Given this list of marker genes NUP98, NLRP6, TP53, NUP153, WNK1, FMR1, SQSTM1, NLRP3, CAPRIN1 (NCBI Gene Id 4076), NEAT1, FUS, LIAT1, FAM81A, DAXX, NCK1, AR, ALKBH5, LGALS3, BRD3, PRNP, NFE2L2, WNK3, HNRNPA2B1, G3BP1, MKI67, SYT1, BLNK, NLRP1, DDX4, MYOZ1, MAVS, UBQLN2, G3BP2, FXR1, SOS1, CGAS, ADGRL3, TARDBP, ZAR1, CARD8, EZH1, CCNT1, MECP2, LAT, SURF6, MSI1, RXRG (NCBI Gene Id 6258), SPATA18, CIDEC, here is a description of the gene set: species: Homo sapiens Human Gene Set: GOMF_MOLECULAR_CONDENSATE_SCAFFOLD_ACTIVITY Binding and bringing together two or more macromolecules in contact, permitting those molecules to organize as a molecular condensate.